Given this list of marker genes CD59 (CD59 molecule (CD59 blood group)), MYH9, TSPAN5, MYOC, ATF5, PITPNB (NCBI Gene Id 23760), here is a description of the gene set: Best trans-regulated quantitative trait loci (QTLs) in the mouse genome which modulate transcription in brain tissue. Patterns of gene expression in the central nervous system are highly variable and heritable. This genetic variation among normal individuals leads to considerable structural, functional and behavioral differences. We devised a general approach to dissect genetic networks systematically across biological scale, from base pairs to behavior, using a reference population of recombinant inbred strains. We profiled gene expression using Affymetrix oligonucleotide arrays in the BXD recombinant inbred strains, for which we have extensive SNP and haplotype data. We integrated a complementary database comprising 25 years of legacy phenotypic data on these strains. Covariance among gene expression and pharmacological and behavioral traits is often highly significant, corroborates known functional relations and is often generated by common quantitative trait loci. We found that a small number of major-effect quantitative trait loci jointly modulated large sets of transcripts and classical neural phenotypes in patterns specific to each tissue. We developed new analytic and graph theoretical approaches to study shared genetic modulation of networks of traits using gene sets involved in neural synapse function as an example. We built these tools into an open web resource called WebQTL that can be used to test a broad array of hypotheses. species: Mus musculus from publication Chesler EJ, Lu L, Shou S, Qu Y, Gu J, Wang J, Hsu HC, Mountz JD, Baldwin NE, Langston MA, Threadgill DW, Manly KF, Williams RW (PMID 15711545) Human Gene Set: CHESLER_BRAIN_QTL_TRANS